Given this list of marker genes CYP4A11, CYP2A7, CYP2F1, CYP2A13, CYP4F11, CYP4F3, CYP2D6, CYP4F12, CYP2J2, CYP4F8, CYP4A22, CYP4F22, CYP4B1, CYP2B6, CYP4F2, here is a description of the gene set: Human Gene Set: REACTOME_FATTY_ACIDS Fatty acids species: Homo sapiens